Given this list of marker genes TRMT44, PLD4, FYB1, CARD11, MS4A6A, ARHGAP25, HLA-DRA, TRPM2, PLK3, INPP5D, IL6R, CSF2RA, ADCY7, ITGAM, DOCK8, PIK3AP1, TLR2, MERTK, PIK3R5, PTAFR (NCBI Gene Id 91527), RGS1, RAB20, LRRK1, TRAF3IP3, MAST3, C1QB, LINC02798, LPCAT2, RHBDF2, RELL2, ELF4, LY86, RUNX1, LAT2, DOCK11, FGD2, NAIP, AZIN2, TMEM106A, ZFYVE19, SPN, MS4A7, KLRK1-AS1, SRGAP2C, F13A1, VSIG4, CD83, CD14, PLEK, RUNX2, CLEC7A, GMIP, VAV1, YES1P1, CD37 (CD37 molecule), IKZF1, ENSG00000258168, CRAT37, SPI1, ITGB2, FBP1, LAPTM5, LINC02642, GPR34, IRAG2, XACT, MKNK1, EGR3, DOCK2, CD74, HLA-DMA, TBXAS1, CD163L1, RHOH, LCP1, FGD3, SLC7A7, KCNK13, ITPR2, CD84, NCKAP1L, ADAM28, P2RY12, GLIPR1, FMNL1, STAB1, LINC02712, HLA-DRB1, TSPOAP1-AS1, CX3CR1, SCIN, C1QC, SLCO2B1 (solute carrier organic anion transporter family member 2B1), SMIM35, ARHGAP15, OLR1, LGMN, KBTBD8, HLA-DPA1, ARHGAP22, CD247, SMAP2, ITGAL, RNASET2, ATP8B4, TFEC, HPGDS, SIGLEC10, MYO1F, ARHGAP30, IL10RA, APBB1IP, WDFY4, SLC9A9 (solute carrier family 9 member A9), GAL3ST4, SKAP1, S100Z, TIGD4, TMEM144, CCDC26, SPP1, CLPB, CYTH4, CCL2, ST6GAL1, NCF2 (NCBI Gene Id 4688), IRF8, NRROS, MIOS (NCBI Gene Id 54468), WHAMMP4, TXK, PRAM1, LYVE1, CDCA5, C1QA, BANK1, JAK2, GAS6-AS1, SP140, RASGEF1C, CSF1R, CYSLTR1, CYBB, AOAH, LRRC43, PTPRC, IPCEF1, PTPN22, EFCAB14-AS1, ADAP2, CSF3R, GPR183, HCK, here is a description of the gene set: The gene expression program underlying the specification of human cell types is of fundamental interest. The study authors generated human cell atlases of gene expression and chromatin accessibility in fetal tissues. For gene expression, the study authors applied three-level combinatorial indexing to >110 samples representing 15 organs, ultimately profiling ~4 million single cells. The study authors leveraged the literature and other atlases to identify and annotate hundreds of cell types and subtypes, both within and across tissues. Our analyses focused on organ-specific specializations of broadly distributed cell types (such as blood, endothelial, and epithelial), sites of fetal erythropoiesis (which notably included the adrenal gland), and integration with mouse developmental atlases (such as conserved specification of blood cells). These data represent a rich resource for the exploration of in vivo human gene expression in diverse tissues and cell types. Human Gene Set: DESCARTES_FETAL_EYE_MICROGLIA Marker genes curated from the annotated cluster as represented in the Descartes Human Gene Expression During Development database. from publication Cao J, O'Day DR, Pliner HA, Kingsley PD, Deng M, Daza RM, Zager MA, Aldinger KA, Blecher-Gonen R, Zhang F, Spielmann M, Palis J, Doherty D, Steemers FJ, Glass IA, Trapnell C, Shendure J (PMID 33184181) species: Homo sapiens